The following is a description of a gene set: Mouse Gene Set: GOBP_REGULATION_OF_MYELINATION species: Mus musculus Any process that modulates the frequency, rate or extent of the formation of a myelin sheath around nerve axons., and this is the list of marker genes: Akt1, Nrdc, Pard3, Eif2ak3, Cst7, Tenm4, Qki, Tmem98, Dicer1, Sgms1os1, Tnfrsf21, Ctsc, Egr2, Tnf, Mir23a, Lpin1, Hes5, Tcf7l2, Ctnnb1, Tppp, Hgf, Ifng (NCBI Gene Id 15978), Dlg1, Dag1, Mir219a-2, Sox10, Lgi4, Cdk18, Fig4, Srebf2, S100b (S100 protein, beta polypeptide, neural), Mtor, Rxra (NCBI Gene Id 78740), Mtmr2, Cyfip1, Jam2, Ptn, Mir219a-1, Rarb, Myrf, Tymp, Sirt2, Mag, Itgax, Rara, Wasf3, Pten, Ncmap, Rxrg, Ptprz1, Ngfr, Rxrb (NCBI Gene Id 20182), Nsun5, Tg (thyroglobulin), Kif14, Slc25a12, Zpr1, Tnfrsf1b, Rnf10, Trf, Cdh2, Hnrnpk, Igf1, Zfp488, Rarg